Given this list of marker genes Bmp5, Greb1l, Ctnnb1, Hoxd13, Srd5a2, Shh, Asb1, Klhl10 (NCBI Gene Id 66720), Pdgfra, Bmp6, Tbx3, Tex15 (NCBI Gene Id 73664), Fgf8, Sycp2, Sox2 (NCBI Gene Id 20674), Ar, Hoxa13, Lgr4, Wnt9b, Dhcr24, Fgf10, Wt1, here is a description of the gene set: species: Mus musculus Mouse Gene Set: GOBP_MALE_GENITALIA_DEVELOPMENT The process whose specific outcome is the progression of the male genitalia over time, from its formation to the mature structure.